Given this list of marker genes Atp7a (ATPase, copper transporting, alpha polypeptide), Mmgt2, Slc39a11, Slc31a1, Atp7b (NCBI Gene Id 11979), Slc46a3, Slc31a2, Slc11a2, here is a description of the gene set: Enables the transfer of copper (Cu) ions from one side of a membrane to the other. studied in species Mus musculus Mouse Gene Set: GOMF_COPPER_ION_TRANSMEMBRANE_TRANSPORTER_ACTIVITY